Given this list of marker genes BRAF, PRKAR1A, CDK4 (NCBI Gene Id 92978), PDE11A, STK11, here is a description of the gene set: Atypical nevi in non-sun exposed areas studied in species Homo sapiens Human Gene Set: HP_ATYPICAL_NEVI_IN_NON_SUN_EXPOSED_AREAS